Given this list of marker genes NDN, CYP11B1, OCA2, TAF4, USP7, MAGEL2, SIM1, SNRPN, HSD3B2, GRB10, here is a description of the gene set: Premature adrenarche Human Gene Set: HP_PREMATURE_ADRENARCHE studied in species Homo sapiens Onset of adrenarche at an earlier age than usual.